The following is a description of a gene set: Human Gene Set: GOMF_OXIDOREDUCTASE_ACTIVITY_ACTING_ON_A_SULFUR_GROUP_OF_DONORS_NAD_P_AS_ACCEPTOR species: Homo sapiens Catalysis of an oxidation-reduction (redox) reaction in which a sulfur-containing group acts as a hydrogen or electron donor and reduces NAD or NADP., and this is the list of marker genes: TXNDC17, NXN, GSR, TXN, PGK1, SELENOT, TXNRD3, TXNRD1, TXNRD2, TXNDC2, DLD